Given this list of marker genes DACH1, DDIT3, STK40, NDST1, FUT8 (fucosyltransferase 8), PHOX2B, DRC1, HIPK2, ADH5, CC2D1A, VANGL1, GRP, PASK, SFTPA2, DCAF11, FKRP, HNMT, NMB, NTSR1, BLOC1S6, NLGN2, CFAP43, CCDC88C, FTO, ZFAND5, BPGM, COX5B, MTG2, CFAP221, NR4A2, GSX2, NLGN3, MAN2A1, EDNRA, GLS, STARD7, COL6A1, MAN1A2, PBX3, CYSLTR1, CHST11, UCP3, GAA, CCBE1, SFTPB, TNNC1, FLT4, ADORA1, PHOX2A, SELENON, TRAF4, NMBR, MAFB, JAG2, SPAG16, EDN1, NDN, AP3B1, TLX3, HOXA5, ELN, MECP2, DNAH9, ECEL1, MTG1, RAB3A, TCF15, GLRA1, ODAD4, CFAP54, TMPRSS11D, GRPR, TTLL1, SFTPC, CSF2RB, YWHAZ (tyrosine 3-monooxygenase/tryptophan 5-monooxygenase activation protein zeta), TAS2R4, SFTPD, ATP1A2, SFTPA1, TSHZ3, NEK10, here is a description of the gene set: The process of gaseous exchange between an organism and its environment. In plants, microorganisms, and many small animals, air or water makes direct contact with the organism's cells or tissue fluids, and the processes of diffusion supply the organism with dioxygen (O2) and remove carbon dioxide (CO2). In larger animals the efficiency of gaseous exchange is improved by specialized respiratory organs, such as lungs and gills, which are ventilated by breathing mechanisms. studied in species Homo sapiens Human Gene Set: GOBP_RESPIRATORY_GASEOUS_EXCHANGE_BY_RESPIRATORY_SYSTEM